The following is a description of a gene set: Human Gene Set: HP_WEAK_CRY Weak cry species: Homo sapiens, and this is the list of marker genes: ATRX, GFPT1, RYR1, NDUFS8, IGHMBP2, CRYAB, SYT2, MPV17, ASPA, SNAP25, RAPSN, ASAH1, MYO9A, LAMA2, SLC25A1, IFT56, GGPS1, LAMA3, LAMB2, VAMP1, SCN4A, KDM6A (lysine demethylase 6A), PEX19, VPS13B, KMT2D, UBA1, OPA1, PPP1R21, NIPBL (NCBI Gene Id 25836), COL13A1, CHRNE (cholinergic receptor nicotinic epsilon subunit), CHRND, FTO, VARS1, TPM3, LYRM4, HACD1, CHRNA1, CHAT, TRIP4, SIM1, SLC18A3 (NCBI Gene Id 6572), FKTN, COLQ, SLC5A7, EXOSC9, AGRN, MAGEL2, SNRPN, COQ9